Given this list of marker genes Npr2, Wnt5a, Camk2b, Msx2, Fbxo43, Igf1r, Grb14, Gpr3, Prkacb, Dusp1, Spata22, Msx1 (NCBI Gene Id 269644), Fbxo5, Insr, Cntd1, Npm2, Meioc, Aspm, Rps6ka2, Prdm9, Pde3a, Lif (NCBI Gene Id 16878), Nanos2, Trip13, Rad51ap1, Psma8, Fzr1, Dmrt1, Dazl, Ythdc2, Ooep, Prkaca (protein kinase, cAMP dependent, catalytic, alpha), Pkmyt1, Rad1, Eif4g3, Gja1, Cdc25a, Knl1, Cdc25c, Lfng, Stk35, Rbm46, Calr, Osm, Mapk15, Plcb1, Wee2, Sirt2, Cdc25b, Ovol1, Hormad1, Mos, Chfr, Zwint, Meiosin, Zfy2, Nppc, Cdc20, Wnt4, Mettl3, Ttk, Piwil2, Stra8, Pdik1l, Ube2b, here is a description of the gene set: species: Mus musculus Any process that modulates the rate or extent of progression through the meiotic cell cycle. Mouse Gene Set: GOBP_REGULATION_OF_MEIOTIC_CELL_CYCLE